Given this list of marker genes SYNJ1, PIDD1, SPG7, PODXL, DNAJC6, MAPT, here is a description of the gene set: species: Homo sapiens Slowed slurred speech Human Gene Set: HP_SLOWED_SLURRED_SPEECH